The following is a description of a gene set: Any process that modulates the frequency, rate or extent of the process of directing proteins towards a membrane, usually using signals contained within the protein. species: Mus musculus Mouse Gene Set: GOBP_REGULATION_OF_PROTEIN_TARGETING_TO_MEMBRANE, and this is the list of marker genes: Pak1, Ogt, Usp17le, Kcnb1, Mtcl1, Grin2a, Prnp, Gdi1, Cdk5r1, Arpc2, Ank3, Dmtn, Cdk5, Slc51b, Hras, Cib1, Erbb2, Fyn (Fyn proto-oncogene), Mff, Stom, Chp1, Hpca, C2cd5, Slc1a1, Akt2, Myo1c, Itgb1bp1, Ccl2, Tcaf1, Fis1, Itgam (integrin alpha M), Actr3, Mief2, Mief1, Tent2, Pdzk1, Kcne1, Inpp5k, Cemip, Cacnb3